Given this list of marker genes Nhlh2, Plxna3, Nrp1, Nrp2, Pou3f2, Prop1, Otp, Prdm13 (NCBI Gene Id 230025), Ndnf, Plxna1, Hap1, Sema3a, Sema3e, Ubb, here is a description of the gene set: The differentiation of cells that will contribute to the structure and function of the hypothalamus. species: Mus musculus Mouse Gene Set: GOBP_HYPOTHALAMUS_CELL_DIFFERENTIATION